Given this list of marker genes TAF12, CHTF8, FAM83B, AMD1, RUNX1, FOXN3, SERPINE1, IL6ST, CPEB2, EDA2R, IKZF2, ZNF716 (NCBI Gene Id 442554), PIK3R1, SLC10A2, TMED6, DSE, CNTN1, SUCO, STRN3, EIF4E2, ANO1, CDH7, LRRN3, TTLL5, MEX3C, LRRC55, GRK6, ABHD13 (abhydrolase domain containing 13), SRGN, NUFIP2, VPS53, RASGRF2, ADGRL2, MPLKIP, MAP3K7CL, SCN8A, TERF1, CAMKK2, BMPR2, ARID4A, PANK1, SEMA4G, MOCS2, WSB1, NR3C1, HIP1 (huntingtin interacting protein 1), ZCCHC24, TRIM58, MECP2, SLC39A11, DNAAF6, PIF1, MYH7B, NAT8L, SMAD1, ISYNA1, CELF5 (CUGBP Elav-like family member 5), IL20RA, here is a description of the gene set: from publication Chen Y, Wang X (PMID 31504780) studied in species Homo sapiens Human Gene Set: MIR4646_3P Genes predicted to be targets of miRBase v22 microRNA hsa-miR-4646-3p in miRDB v6.0 with MirTarget v4 prediction scores > 80 (high confidence targets).